Given this list of marker genes IQCH, CDH10, PTBP1, SMG7, QSER1, EVL, N4BP3, SRSF3, ARHGEF9, TYK2, EXO5, C1orf159, TRDV2, CTSS, BLCAP, FAM171A1, APPL2, GSTK1, STIMATE, CENPB, FAM168B, ID3, RANGAP1, SEMA3D, ITFG1, S100A4, SPINT3, KCTD13, CMTR1, RGS13, TUBB4B, OGFOD1, PLAC8, RAP2B, USP18, RSAD1, IFI6, PPP3CC, TTC19 (NCBI Gene Id 54902), NELFA, RPL11, CDCA8, PMS2P3, FAF1, SURF2, PLSCR1, IRAK3, NCAM2, CHL1, TMEM62, OAS3, DHX35, TSPAN12, CLEC2D, ABCA7, ATF5, ACTR8, KLC2, IFI27, SGSM3, ESYT1, RC3H2, ITIH4, SRGN, NUP210, SYCP2, BST2, ZNF551, CD52 (NCBI Gene Id 1043), UBE2L6, PFDN1, IRS1, TAF6, SPATA31F2P, DDC, PLXDC1, PLA2G6, RSAD2, CD55, EPHB6, CCNI, LARP4B, MX2 (MX dynamin like GTPase 2), RAB8A, CAPG, STOML1, RNF19B, CUL4A, KPTN, PTPRJ, RETREG3, USP11, IFITM3, PRKACA, EIF2AK1, SEMA3G, HTN1, ISG15, PLEKHO1, VIM, SCML2, SERPINF1, PCLAF, IFIT1, MICU1, DCTN1, CYP7A1, SCAP, RNF123, PRKAB1, ISG20, PILRB, ITGB7, MAP3K7, KCTD5, WDR6, TSSC4, CALM3, TUBGCP5, TBC1D8, IGBP1, CCR7, CDH9, NFATC3 (NCBI Gene Id 82543), LARP1, DIAPH3, SMARCA5 (NCBI Gene Id 8467), SNRNP35, PPBPP2, CIRBP, WBP11, ERBB2, FGF8, MZT2B, LGALS3BP, ANKRD36BP2, TMEM127, CD27, NFATC1, VAMP8, HGS, ZKSCAN8, TTC12, SF3A2, TMOD2, CD247, KERA, MINAR1, IL4R, SPTAN1, ZNHIT1, STEAP4, CXCL13, FICD, OSGEP, RELB, ANKRD13C-DT, MAP2K6, PDE4DIP, MS4A12, IER2, KMT2D, GRHPR, RPLP1, IFT22 (intraflagellar transport 22), MX1, ACTN4, IFITM1, ROBO3, SEMA3E, AGK, SLC2A4RG, SIN3B, OMG, NDUFS6, RNF186, ST20, BABAM1, GIT2, IFIT3, MBD3, MRTFA, MIS18BP1 (NCBI Gene Id 55320), SH2B3, KLF9, BHLHE41, QDPR, UBOX5, ADRM1, APOH, CTDSPL, GPR137B, IFI44L, CDK18, TRIM66, OAS2, here is a description of the gene set: Human Gene Set: GSE1925_CTRL_VS_24H_IFNG_STIM_MACROPHAGE_UP IFN-gamma transcriptional responses in control and IFN-gamma primed primary human macrophages Genes up-regulated in macrophages: untreated versus stimulated by IFNG for 24h. studied in species Homo sapiens from publication Hu X, Park-Min KH, Ho HH, Ivashkiv LB (PMID 16148108)